Given this list of marker genes OIP5 (Opa interacting protein 5), LCLAT1, SNX16, ZBTB22, SYNDIG1L, UBE2H, PTPN4 (NCBI Gene Id 5775), ANGPT2, INO80D, BCDIN3D, H2AZ1, CYFIP1, FZD3, ZXDB, IGF2BP3, VCPIP1, SLC30A6, LMO4, CTNNA3, CCR2, THAP9, SLC18A2, ZNF25, YWHAG, ASIC1 (acid sensing ion channel subunit 1), PHLPP1, MRPL11, ZCCHC14, GADL1, CENPW, NFE2L1, ST7, APBA1, SLC16A10, SLC35F1, SLAIN2, ZNF772, CRNN, KRT2, SYNPO2, PPP2R1B, RFX7, RDH10, SIM1, MED27 (mediator complex subunit 27), SLC26A8, LDLRAD3, NFIB, CNTNAP4, WDFY3, SERTM1, TUBB4A, SNTB2, NRXN1, KCNIP1, THUMPD1, RHOQ, TTPAL, RACGAP1, DACH2, ERC2 (NCBI Gene Id 26059), ITGA10, BOC, ZNF234, STC2, MACIR, BRPF3, SMIM18, COL5A2, HYCC2, PIAS2, UBE2W, CPEB2, LUC7L3, SAMD13, SPHKAP, CERS6, SMNDC1, WWTR1, ZNF268, DYNC1I2 (dynein cytoplasmic 1 intermediate chain 2, NCBI Gene Id 1781), FAM222A, CDYL2, VRK2, RAB3D, FMN1 (NCBI Gene Id 649014), TAC1, ZNF519, SAMD8, TRPC1, IFT56, GPATCH2, GJA5, PPAT (phosphoribosyl pyrophosphate amidotransferase), SLC2A10, L2HGDH, KIAA1549L, KATNBL1, DCUN1D1, SSPN (sarcospan), FOXN2, TBC1D22B, GXYLT1, ZNF384, TRIB1, ANKRD63, CDK4, GK5, LARP1, RIPK2, PRSS16, TRDN, AGFG1, TAF15, here is a description of the gene set: Genes predicted to be targets of miRBase v22 microRNA hsa-miR-4756-3p in miRDB v6.0 with MirTarget v4 prediction scores > 80 (high confidence targets). from publication Chen Y, Wang X (PMID 31504780) Human Gene Set: MIR4756_3P species: Homo sapiens